Given this list of marker genes Gpr65, Oxtr, Ccr3, Tshr, Opn4, Ccr7, Ece1, C3ar1, Oprd1 (NCBI Gene Id 18386), Sstr2, Cxcl16, Gnrhr, Npy1r, Ednrb, Fshb, Uts2, Ntsr2, Pf4, Cnr2 (NCBI Gene Id 12802), Cxcl3, Avpr2, Cxcl1, Gpr17, Htr1b, Hcrt, Rrh, Ccl9, Taar9, F2rl3, Cxcr4, Gal, Adra2c, Adra2a, Cxcl10, Prok2, Prokr2, Hebp1, Prlhr, Bdkrb1, Hcar2, Ptger2, Ccl4, Hcrtr1, Cga, Bdkrb2, S1pr5, Gpr4, Cxcr5, Tbxa2r, F2, Brs3, Taar1, C3, Lpar3, Rho, Taar3, Cxcr2, Ltb4r1, P2ry2, Sstr4, Trh, Lpar6, Rxfp4, Drd2, Chrm1, Agtr2, Nmu, Insl5, Cxcr6, Penk, Cxcr1, Sst, Opn1sw, Cck, Tac2, Ccl5, Pyy, F2rl1, Adora2a, Kiss1r, Cmklr1, Taar8c, Ptger1, Avpr1a, Ffar2, Cysltr2, Cort, Hrh2, Gpr132, Ccr4, P2ry10, Ccl6, Sstr3, Chrm3, Plppr5, Qrfprl, Mc2r, Galr1, Edn2, C5ar1, Avpr1b, Cxcr3, Htr6, Gphb5, Kel, Ccr10, Cckar, Htr2c, Fpr-rs4, Prokr1, Sucnr1, Cx3cr1, Ppy, Galr2, Nms, Oprl1, Fpr1, Mc4r (melanocortin 4 receptor), Adrb3, Cnr1, Drd5, Pnoc, Opn3 (NCBI Gene Id 13603), Uts2r, Adrb1, Ccl20, Lpar4, Gpbar1 (G protein-coupled bile acid receptor 1), Mc1r, Ccl21e (C-C motif chemokine ligand 21E), Htr7, Ccl11 (C-C motif chemokine ligand 11), Fpr-rs6, Grpr, Opn5, Npffr1 (neuropeptide FF receptor 1), Mchr1, Oxt, Adra2b, Cysltr1, C5ar2, Ackr4, Ackr2, Gpha2, P2ry4, Galr3, Ffar3, Edn1, Edn3, Eef1ece2, Avp, Cxcl9, Psap, Mtnr1a, Cxcl12, Oxgr1, Rxfp3, Htr1f, Ccl3, Trhr, Oprm1, Ptger4, Gpr183, Ccl28, Tacr2, Drd3, Gpr35, Hrh4, Npy2r, Plppr3, Gpr68, Ccl12, Npy4r, Npff, Plppr1, Nmb, Nmur1, Adra1a, Lpar2, Npsr1, Hcar1, Ccl21f, Nmur2, Ptgir, S1pr4, Mc3r, Chrm2, Hc, Prok1, Mc5r, Ptgdr2, Ccl19, Ccl17, Gper1, Rxfp2, Fpr-rs7, Uts2b, Ccl21a, Cxcl2, Taar5, Ccr6, Drd4, Lpar5, Cckbr, Pomc, Htr1a, Ntsr1, Fpr-rs3, Qrfp (pyroglutamylated RFamide peptide), Fshr, P2ry1, Tacr1, Ptgdr, Npw, Hrh3, Grp, S1pr3, Hcrtr2, Chrm4, P2ry13, Kiss1, Kng2, Sstr1, Npb, Htr4, Ccl7, Nts, Xcr1, Taar8b, Rgr, Hrh1, Htr5a, Ffar1, Gpr143, Ccr8, Rln3, Aplnr, here is a description of the gene set: studied in species Mus musculus This event has been computationally inferred from an event that has been demonstrated in another species.<p>The inference is based on the homology mapping from PANTHER. Briefly, reactions for which all involved PhysicalEntities (in input, output and catalyst) have a mapped orthologue/paralogue (for complexes at least 75% of components must have a mapping) are inferred to the other species. Reactome Pathway: Class A/1 (Rhodopsin-like receptors) electronically inferred by orthology from the curated human pathway part of: GPCR ligand binding